Given this list of marker genes Tet2, Ntan1, 6030458C11Rik, Cntn1, Ect2, Adcy3, Zfp629, Cdh7 (cadherin 7, type 2), Hdac9, Rdh9, Bmpr1a, 1700017N19Rik, Morc4, Cpxcr1 (CPX chromosome region, candidate 1), Fbxl2, Wdr64, Sod2, Rock1, Gnas, Cd244a, Hibadh, Chordc1, Slitrk1, Ube2q2, Dna2, Lrba, Atad2, Farsb, Atosb, Zfp462, Crxos, Cdc27 (NCBI Gene Id 268493), Slc25a5, Adk, Sfmbt2, Tdrd5, Niban2, Mefv, Krt32, Celf2, Sp4, Ube2q2l, Dck, Slc35c1, Ythdc2, C030006K11Rik, Rsad1, Nsun7 (NCBI Gene Id 70918), here is a description of the gene set: Mouse Gene Set: MIR_6537_3P species: Mus musculus Genes predicted to be targets of miRBase v22 microRNA mmu_miR_6537_3p in miRDB v6.0 with MirTarget v4 prediction scores > 80 (high confidence targets). from publication Chen Y, Wang X (PMID 31504780)